The following is a description of a gene set: Human Gene Set: GSE13485_DAY1_VS_DAY3_YF17D_VACCINE_PBMC_UP The immune responses generated by YF-17D by profiling genes in 25 vaccine recipients were accessed at days 1, 3, 7, and 21 post-vaccination compared to pre-vaccination in PBMCs. The immune responses generated by YF-17D by profiling genes in 25 vaccine recipients were accessed at days 1, 3, 7, and 21 post-vaccination compared to pre-vaccination in PBMCs. from publication Querec TD, Akondy RS, Lee EK, Cao W, Nakaya HI, Teuwen D, Pirani A, Gernert K, Deng J, Marzolf B, Kennedy K, Wu H, Bennouna S, Oluoch H, Miller J, Vencio RZ, Mulligan M, Aderem A, Ahmed R, Pulendran B (PMID 19029902) species: Homo sapiens Genes up-regulated in comparison of unstimulated peripheral blood mononuclear cells (PBMC) 1 day after stimulation with YF17D vaccine versus PBMC 3 days after the stimulation., and this is the list of marker genes: CCN1, EMID1, THY1, FHOD3, TNN, IQUB, GRHL2, CDCP1, FNDC4, GRIN2A (NCBI Gene Id 2903), ADGRG7, HSPB8, TNFSF18, VTI1A, VWA3A, OTUB2, ITGB6, DYNLT2, DLX2, LINC01720, FAM78B, COL18A1-AS1, DNAJB13, ASB10, TIMP3, POM121L2, GSTA3, SLC34A3, HTR3C, SCG2 (secretogranin II), BEST1, A4GNT, LMX1A, EGFR, TAC3, FRMD1, ELFN2, SLC22A8, MAPK12, AADAC, LINC00520, GLRA2 (glycine receptor alpha 2), PLA2G10, CPN2, LINC01343, GAB4, WSCD2, SERPINA7, FBLN1, KRT7, PANX2, RPL3, MRGPRX4, BCL9L, USP5 (NCBI Gene Id 8078), KRT5, MAGIX, IL11, WDR72, DMWD, CYP3A7, ENSG00000176984, MNX1, PHOX2B, C8B, CA8, KIAA1614, C5orf58, NOBOX, APLNR, PCDHB1, SEC16B, C11orf16, CDH26, CFAP69, TMEM190 (NCBI Gene Id 147744), EDARADD, ADAD1, PCLO (NCBI Gene Id 56630), KRTAP4-12, RSU1P2, EDA2R, ZNF295-AS1, POM121L12, INE1, ARFGEF3, DUSP8, VN1R2, SRRM3, TMEM92, TMEM95, PAX1, MIR124-1HG (MIR124-1 host gene), CACNG4, TMCO2, PYY2, GARIN2, USH1C, KCNJ12, FKBP6P2, OR1D2, ECM2, ZNF843 (NCBI Gene Id 283933), WNT11, ANHX, ZNF257, SLITRK5, PRKCSH, SIGLECL1, DEFB124, OMD, CAVIN1, ZBED3-AS1 (NCBI Gene Id 730772), PKD1L2, KLC3, SLC22A25, IL17RC, FGD1, HDAC11, GRIK1-AS1, EFCAB5, TSACC, DIO2, SPART-AS1, LINC00265, MYOZ3, PKMYT1, KIFC1, SALL3, MYH14, OR2A4, CYP4F2, SPRR2G, MTMR8, ADAM29, GPR26, LINC01226, NAV3, ENSG00000281732, CFAP157, ATCAY, HOTTIP, PCSK1, LINC01010 (long intergenic non-protein coding RNA 1010), SPATA24, ESR2 (NCBI Gene Id 440183), ENSG00000230736, P2RY4, ZNF548, MAS1, LINC00928, HTR1E, ZNF491, SMOC1, SMR3B, CSH1, ACTC1, C9orf163, OR7E104P, KMT2E-AS1, OR7A5, HAGLR (NCBI Gene Id 401022), SH2D4A, WFDC1, OGFRP1, LINC01512, ASB12, ANKRD30BP3, OR1C1, PDCD1LG2, LINC02907, GK2, FBXL18, TRIM67, CPXM2, TNS4, RXFP2, TUBAL3, NKX3-1, SPHKAP (NCBI Gene Id 80309), CDX1, PPP1R1B, ANKRD53, NRAP, SAMD15